Given this list of marker genes Ptp4a2, Agrn (NCBI Gene Id 381587), Cox10, Pggt1b, Chm, Aipl1, Fntb, Musk, Chml, Fnta, Rabggta, Rabggtb, Plpp6, here is a description of the gene set: The covalent attachment of a prenyl group to a molecule; geranyl, farnesyl, or geranylgeranyl groups may be added. studied in species Mus musculus Mouse Gene Set: GOBP_PRENYLATION